Given this list of marker genes POU3F2, NFIA, MLLT3, IGFBPL1, EZR, DDAH2, ZBTB20, MEIS2, MDK, ZFHX4, PPP2R2B, HSPA1B, NFIB, PANTR1, PHLDA1, ENC1, here is a description of the gene set: Human Gene Set: FAN_EMBRYONIC_CTX_EX_2_EXCITATORY_NEURON from publication Fan X, Dong J, Zhong S, Wei Y, Wu Q, Yan L, Yong J, Sun L, Wang X, Zhao Y, Wang W, Yan J, Wang X, Qiao J, Tang F (PMID 29867213) studied in species Homo sapiens